Given this list of marker genes EXTL2, PREB, PPP2R5B (protein phosphatase 2 regulatory subunit B'beta), ATP6V0D1 (NCBI Gene Id 9114), SRPRA, LMNA (NCBI Gene Id 7816), HDGF, GOSR2, DCTN1, SRPRB, KLHDC3, SEC31A, YIF1A, CTDSP2 (CTD small phosphatase 2), SERP1, SULT1A3, SYVN1, DNAJB9, MYDGF, SSR1, ARFGAP1, XBP1, HYOU1, CXXC1, ZBTB17, TATDN2, TSPYL2, WIPI1, DNAJC3, ACADVL, PDIA6, FKBP14, ADD1, DDX11, SHC1, PDIA5, PLA2G4B, KDELR3, WFS1, TLN1, EDEM1, GSK3A, TPP1, EXTL3, DNAJB11, GFPT1, EXTL1, CUL7, here is a description of the gene set: part of: IRE1alpha activates chaperones Reactome Pathway: XBP1(S) activates chaperone genes Xbp-1 (S) binds the sequence CCACG in ER Stress Responsive Elements (ERSE, consensus sequence CCAAT (N)9 CCACG) located upstream from many genes. The ubiquitous transcription factor NF-Y, a heterotrimer, binds the CCAAT portion of the ERSE and together the IRE1-alpha: NF-Y complex activates transcription of a set of chaperone genes including DNAJB9, EDEM, RAMP4, p58IPK, and others. This results in an increase in protein folding activity in the ER. species: Homo sapiens